Given this list of marker genes C3, C2, C4B_2, C4B, CFB, C5, C4A, CFP, here is a description of the gene set: studied in species Homo sapiens Activation of C3 and C5 Human Gene Set: REACTOME_ACTIVATION_OF_C3_AND_C5